Given this list of marker genes Prap1, Brd4, Ppp1r10, Aurka, Mad2l1bp, Ska1, Ska3, Mad1l1, Chek2, here is a description of the gene set: studied in species Mus musculus Any process that stops, prevents or reduces the frequency, rate or extent of cell cycle checkpoint. Mouse Gene Set: GOBP_NEGATIVE_REGULATION_OF_CELL_CYCLE_CHECKPOINT